The following is a description of a gene set: Genes up-regulated in comparison of memory CD4 T cells from young donors treated with TSST at 72 h versus those from old donors treated with TSST at 72 h. With increasing age, the ability of the immune system to protect against recurring infections or to control chronic infections erodes. The objective of the current study was to identify gene expression signatures in elderly CD4 T cell responses studied in species Homo sapiens Human Gene Set: GSE36476_YOUNG_VS_OLD_DONOR_MEMORY_CD4_TCELL_72H_TSST_ACT_UP from publication Yu M, Li G, Lee WW, Yuan M, Cui D, Weyand CM, Goronzy JJ (PMID 22434910), and this is the list of marker genes: SLC2A9, WNT3, TUSC2, CENPM, RAD51D, CBFA2T3, ESRRG, DUS2, NEFH, AAMDC, CACNB2, DGCR5, CXCL8, LAMA1, CHAF1A, TTC38, HECW1, STK24, PDE11A, HAVCR1, RBMY2FP, LMAN2L, NPHP4, GP6, PPP4R4, GRM4, TAF15, DNMT3B, PEX26, ADIPOQ, MAGEA8, TM4SF4, CD8B, IL33, TFF2, TAS2R3, PCDHB13, MTMR11, FEZ1, BEAN1, JPT1, TNMD, ADARB2, PDLIM4, PXDN, S100A7, ABCB1, CPLANE2, MC4R, GPR12, DACH1 (NCBI Gene Id 1602), INSL6, GLRA1, CES1, CR1 (complement C3b/C4b receptor 1 (Knops blood group)), SOX12, COQ7 (NCBI Gene Id 51672), GRM3, LARS1, MFAP3L (microfibril associated protein 3 like), RAB9BP1, PRUNE2, ZNF532, ITGA2, NREP, TSPYL5, EFNB2, NOS2, MATN1, ITIH2, SERPINB7, ECHDC3, RAD54L, PTTG1, MORC1, MYO19, PCBP3, OPRD1, CTSC, PMP2, SPRING1, FANCC, EIF2B5, LRIG2, INCENP, ADGRE2, IBSP, TREML2, FGL1, REEP4 (receptor accessory protein 4), FICD, SCNN1B, MICB, CCL2, CHRNA6, YWHAH-AS1, GRIA1, CPPED1, ATP4A, KRTAP1-3, KNOP1, CCZ1 (CCZ1 homolog, vacuolar protein trafficking and biogenesis associated), MIR124-1HG, TRPV1, NR1D2, IFI27, TRAM2, ZDHHC7, SPATA6, PBX2, HMHB1, SH2D4A, ITGB8, AARSD1, OVOL3, SLC16A8, PPP1R2C, MYBPC2, ZNF157, KCNV2, VCAN, TNPO3, CALB1, XYLB, NDUFB8, CXCL2, EPHA3, PSPN, PCP4, TBC1D8B, CD93, KCNJ6, KIF20B, CA8, FSHR, STK16, KIR2DL2, SELE (selectin E), NUDT1, CARMIL1, HMGB3P30, KHDRBS2, NPTX2, YY2, EPB41, NCL, TPM4, PCDHB12, HMGN1, GNAI1, MYOM2, CEBPD, MYO15A, TNPO1, SLC27A5, HAS1, COL3A1, TNFSF18, SLC5A5, FOXF1, NANS, GFRA1, LDAF1, CFAP68, UGT2B17, GINS2, KIF2C, LTBP1, SLC22A5, PTPRH, OTUD3, DCAF4, ZNF480, PLPP2, PKP3, TMOD2, REN, TTTY14, MSTN, GFPT2 (glutamine-fructose-6-phosphate transaminase 2), MYL3, GTF3A, ITGB1BP2, ARHGEF10L, PODXL, FOXN2, OPTN, DNAAF5, RBPJL, MMP1, EEF1AKMT2, FAM124B, ELOVL6, ZC3H4, CHRNA5, SRP19, CEACAM3, SLC16A10, MAPK8